The following is a description of a gene set: Any process that modulates the frequency, rate or extent of pre-microRNA processing. studied in species Homo sapiens Human Gene Set: GOBP_REGULATION_OF_PRE_MIRNA_PROCESSING, and this is the list of marker genes: TRUB1, LIN28A, LIN28B, HOXB-AS3, BCDIN3D, DGCR8